The following is a description of a gene set: species: Homo sapiens mGluR1-TRPC3 signaling pathway. Pathway ID: N00953. Pathway type: Reference. Pathway class: nt06528 Calcium signaling. Human Gene Set: KEGG_MEDICUS_REFERENCE_MGLUR1_TRPC3_SIGNALING_PATHWAY Pathway Definition from KEGG: Glutamate -> GRM1 -> GNAQ -> PLCB -> IP3 -> ITPR -> Ca2+ -> PKC -| TRPC3 -> Ca2+, and this is the list of marker genes: PRKCA, TRPC3, PLCB2, GRM1, PRKCG, PRKCB, PLCB4, PLCB1, PLCB3, ITPR3, ITPR1, ITPR2, GNAQ